Given this list of marker genes CCDC152, RASSF7, ASB6, AK7, YME1L1, PRX, SV2B, here is a description of the gene set: Genes predicted to be targets of miRBase v22 microRNA hsa-miR-7112-5p in miRDB v6.0 with MirTarget v4 prediction scores > 80 (high confidence targets). from publication Chen Y, Wang X (PMID 31504780) Human Gene Set: MIR7112_5P species: Homo sapiens